The following is a description of a gene set: A nuclear receptor-mediated signaling pathway initiated by an estrogen binding to an intracellular receptor of the nuclear receptor protein family, and ending with regulation of a downstream cellular process, e.g. transcription. Human Gene Set: GOBP_ESTROGEN_RECEPTOR_SIGNALING_PATHWAY species: Homo sapiens, and this is the list of marker genes: NCOA1, PPARGC1B, DEFA1B, TRIP4, DDX17, UFL1 (NCBI Gene Id 23376), NCOA4, KANK2, DEFA3, STRN3, PADI2, LBH, TAF7, SKP2, SRC, UBA5, DDRGK1, PAGR1, CCDC62, CNOT9, SAFB, DDX54, CNOT1, ZNF366, ISL1, PARP1, DDX5, HDAC2, DNAAF4, LATS1, ESR1, RBFOX2, KMT2D, DEFA1, POU4F2, CYP7B1, VPS18, EGLN2, CNOT2, SRARP, ESR2, CARM1, HDAC6, UFM1 (ubiquitin fold modifier 1), FOXA1, WBP2, CDK12, VPS11, AR, BRCA1, HDAC1, TP63, PAK1, MED1, TADA3, UFSP2, FSHR, PHB2